Given this list of marker genes IL12A, TAB2, TNF, IRAK1, TIRAP, IKBKG, CHUK, IKBKB, RELA, TLR1, TLR4, IL6, IRAK4, NFKBIA, IL12B, MAP3K7 (NCBI Gene Id 6885), MYD88, TLR2, NFKB1, TRAF6, here is a description of the gene set: TLR1/2/4-NFKB signaling pathway. Pathway ID: N00435. Pathway type: Reference. Pathway class: nt06517 TLR signaling. Pathway Definition from KEGG: (TLR1,TLR2,TLR4) -> (TIRAP+MYD88) -> (IRAK4+IRAK1) -> (TRAF6+TAK1+TAB2) -> IKK -> NFKBIA -> NFKB => (TNF,IL6,IL12A,IL12B) Human Gene Set: KEGG_MEDICUS_REFERENCE_TLR1_2_4_NFKB_SIGNALING_PATHWAY species: Homo sapiens